Given this list of marker genes ANAPC16, EDNRA, ASPM, GK2, INHBB, SRC, TEX101, ADGRG2, NLRP14, SPAG4, TUBGCP4 (NCBI Gene Id 27229), NCAPH, HOXA10, RPS6KB1, GALNT3 (NCBI Gene Id 2591), ZP4, STK33, ATP2B4, TESK2, PACRG, ZNF296, SHCBP1L, GDF9, MYH9, ETV6, SLCO4C1, CCIN, ARID4A, SKA3, ANKRD31, PAIP2 (NCBI Gene Id 51247), IQCG, SPATA9, ZBTB16, RBP4 (retinol binding protein 4), DRC1, USP17L2, TARBP2, PRKAG1, PARN, TRIP13, YIF1B, AP3B1, ZSCAN2, SSH2, ORC4, DEFB1, H1-9P, LHCGR, AFP, EPC1, TNP1, SPAG16, DUSP13B, HMGB2, SGO2, CATSPER4, PRDX4 (peroxiredoxin 4), CFAP61, SPATA31D3, C3orf62, PGM3, DLEC1, ZFP57, CENPX, ADAM32, PHC2, TSPY1, KMT2D, TYRO3, HUS1B, PPP3R2, MFSD14A, CDC25B, TGFB1, RAD21, TTLL3, XKRY, NUMA1, MYCN, FMN2, PLN, DNMT3A (DNA methyltransferase 3 alpha), PROK2, MORN2, NPR2, REDIC1, TSNAXIP1, FKBP6, HPGDS, ATAT1, GPR149, TDRD5, AGFG2, ACRBP, KIFC1, CFAP53, UBE2J1, CRTAP, DAZ1, ELSPBP1, EED, ZFP42, GGT1, ANTXR2, DDX3Y, GJA10, OOEP, C14orf39 (NCBI Gene Id 317761), CTCF, PMFBP1, IMMP2L, SIRT2, STAG3, MEIOSIN, ADAD2, B4GALNT1, GOLGA2, FNDC3A, SUFU, FAM9C, AXL, SPACA1, MYCBPAP (MYCBP associated protein), CATSPERB, PTTG1, HOXA9, SYNE1, TDRD9, FANCG, XRCC2, SPATA31A6, ATM, HSF5, CFAP119, DNMT3L, EIF2S2, DDX25, DEFB126, PTTG3P (NCBI Gene Id 26255), FAM170A, TTLL5 (NCBI Gene Id 23093), GAMT, RBM46, BCAS2, DCST1, DAZAP1, RIMBP3C, HSPA1L, UBB, ARID4B, MDK, PRDM14, BCL2L10, HERC2, WFDC2, PRKACA, DEAF1, IFTAP (intraflagellar transport associated protein), ASZ1, CDC23, C2CD6, SOHLH1 (NCBI Gene Id 402381), ZCWPW1, DDX4, STK11, STRBP, KATNAL1, KASH5, RAD1, CDC25C, PTX3, TTC21A, ZAR1, SMAD4, SKIL, RAD51D, TBP, WDR77, ATN1, LRRC8A, SPACA3, PTTG2, RAD23B, UBE2Q1, IGF2R, MORC1, KLK14, NCAPD2, SPESP1 (NCBI Gene Id 83599), SLC2A8, ZNF830, NPPC, CT55, UBXN8, PIWIL3, TBC1D21, BRD2, H3-3A, NANOS2, SPIN1, PLB1, DCAF13, RBM7, SLC26A3, ACE, AR, CDK1, PDCL2, RAB24, BPY2B, WASHC5, ADAM20, ANAPC5, PPP1CC, DMRT1, PMCH, NEURL1, HORMAD2, SNU13, ZC3H14, ZW10, LGR4 (NCBI Gene Id 55366), NR2F2, FST, ARMC3, DLD, GARIN1B, SHB, KAT5, TTC12, PRKG1, PRR19, CCDC38, H3-3B, FAM9B, RNF151, HEXA, CTNNB1, CCNB1, MGAT4D, CCNE2, OR10J1, SPATA6L, TEX15, SPACA5, ANAPC13, RBX1, COX7B2, ADAMTS16, DIAPH2, NR0B1, HROB, SPACA6, H2BC1, BRDT, SPO11, HOATZ (NCBI Gene Id 399949), NME5, YY1, BCL2L2, ANG, FOXO3, KDM3A, USP26, ARMC2, GJA1, YTHDC1, RNF2, GSK3A, ZFP41, FAM50A, ASH1L, SERPINA5, KHDRBS1, CDC25A, CDC27, DZIP1, OSBP2, TRPC3, YTHDF2, MEI1, TUBG2, USP9Y, PLCD4, SYCE1, TSPY2, ADGB, WEE2, RAD21L1, NR2C2, VDAC2, PRM3, ETV5, PTCH1, ANKRD49, APOB, WNT3, MAST2, BPY2, ACTR2, TTLL8, TMEM232, RAD51, HEXB, HERPUD2, ZNF318, DAZ3, SPIRE1, PDILT, OR1D2, GHSR, BRME1, DUSP1, CALR3, FBXO5, SIRT1, SMC2, RXFP2, DND1, UTP14C, CRKL, DAZ2, DHX36, UPF3A, TTLL1, M1AP, PRSS37, FAM209A, AAAS, GLIPR2, TCFL5, TOP3A, CDC16, SHISA6, ZP2, METTL14, NSUN2, CCNYL1, SLC2A14 (solute carrier family 2 member 14), DDX3X, LIMK2, CRISP3, SPATA31A5, SPATA31A1, SPACDR, CCDC136, CALR (NCBI Gene Id 811), NEK2, TOP6BL, FIGNL1, DRC7, MOS, SPANXB1, PTGDS, PKDREJ, ADIG, ESPL1, SPAM1, TBPL1, VIPAS39, FOXL2, AURKA, WDR33, CFAP57, CCT4, MLH1, SEPTIN1, CYLC2, TPPP2, TOPAZ1, ODF4, ACVR2A, EREG, SYT6, FIGLA, ALDOA, SGPL1, RACGAP1, LYZL4, CCDC62, WIPF3, PFN4, BBS4, SUN1 (Sad1 and UNC84 domain containing 1), RPL39L, LRRK2, GLIPR1, LHFPL2, USP9X, PSMD13, TSPY9, PLK1, NDRG3, ZNF148, CATSPERG, PSMA8, MSX1, DCAF17, CFAP65 (cilia and flagella associated protein 65), MCM9, SLC26A8, RUVBL1, TUBB8, SOX8, TAF7L, AKT1, SPATA31C1, ADCY3, SPEM3, SPACA7, SLIRP, SGO1, LARP7, ACTL7A, FANCL, TBC1D20, GGN, PIAS1 (protein inhibitor of activated STAT 1), SEPTIN7, DNAAF3, STRA8, BRCA2, PPP2CA, KLHL10, UNC13B, TSGA10, IZUMO1R, CFAP69, REC114, INCENP, PYGO2, BMAL1, STAT3, TEX14, MAK, SPMAP2, PRSS55, PIWIL1, SYCE1L, SLX4, SPINK13, IFT81, STAG2, CELF4 (CUGBP Elav-like family member 4), ANAPC15, TOP2A, STAU2, PPP2R1A, PRKACG, CATSPERD, SPA17, RAD54B, FETUB, TUBGCP6, NR5A2, KIAA0319L, TDRKH, SPATA46 (spermatogenesis associated 46), CCDC146 (coiled-coil domain containing 146), SMC3, ICA1L, AFG2A, ZNF541, VPS54, TEX11, SETX, ADAMTS2, CFAP221, ZNF449 (NCBI Gene Id 353278), MLH3, TSPY4, SCAPER, ATP8B3, PRMT7, ASF1B, PLEKHA1, BAX, CEP131, TOP2B, PCYT1B, UBE2B, SEPTIN6, H1-8, FOXC1, GMCL2, CCDC63, AGFG1, NEURL4, INSR, SOHLH2, ANKLE1, FSIP2, H3-4, SUN2, CTCFL (CCCTC-binding factor like), SPATA31A7, CCNB2, LIN28A, CNTLN, JAM2, GLI1, TCP1, C1orf146, SERPINA10, H1-1, NANOS3, FOXJ1, SPAG8, CCT5, CHD5, NOX5, C9orf78, EDN1, YTHDC2, TXNRD3, QKI, MTA2, CDKN1C, YBX2, RAD51B, NCAPD3, COL6A1 (collagen type VI alpha 1 chain), SPATA32, VPS13B, ROPN1, MCM8, SYCP1, PUM1 (NCBI Gene Id 9698), DAZL, LIF, TERB2, HMGA2, MND1, ANAPC4, OSGIN2, LLCFC1, FCRL5, CFAP206 (NCBI Gene Id 154313), NBN, ADAM7, NDN, PDIK1L, FREY1, PAEP, EHMT2, KRT9, CHFR, TCP11X1, OVCH2, CBY3, CABS1, MEIKIN (NCBI Gene Id 730865), PLCZ1, CETN2, PYGO1, ITPR1, PKMYT1, SUN5 (NCBI Gene Id 140732), CCDC34, TRIM75, TGFBR1, RAD51AP1, NTRK1, ZPBP2, FBXO24, ZP3, CGB3, LEPR, PCDH11Y, GPX4 (glutathione peroxidase 4), DPCD, CENPC, GNPDA1, RB1, INPP5B, TMEM81, TRIM36, TNP2, PGAM2, SPATA6, INTS13, BBS1, CCDC159, ACTL9, CIB1, FUT6, OVGP1, ACTR3, NICOL1, MMP19, NODAL, CGB7, FSHB, CHN2, GPR3, TBATA (NCBI Gene Id 219793), SASS6, RNF212B, BBS2, ITGB1 (NCBI Gene Id 3688), TUBGCP2, OR7C1, RNF114, CREB3L4, ASTL, MSH4, KNL1, SOD1, DDX20, CLOCK, SKA1, BRIP1, CCNE1, MMP2, CCNY, SYT8, TAF1L, RAN, OAZ3, CFAP58, CCNB3, MEI4, SYCP2, PGR (NCBI Gene Id 5241), SPIN2B, KIT, KCTD19, OR2H2, H1-7, CDC20, DNALI1, CELF3, RNASE10, ANAPC10, CCDC87, MTOR, MEA1, RFX2, EME2 (NCBI Gene Id 390668), SPATC1L, PLCB1, NKAPL, ADAM29, H1-6, CCDC42, CFAP97D1, SIRT7, NECTIN2, NOBOX, PAFAH1B3, MCIDAS, SLC19A2, SLC4A2 (NCBI Gene Id 96677), TSPAN8, KLC3, TUT7, GTSF1, FANCD2, SEPTIN2, FSHR, TPGS1, ADAM2 (ADAM metallopeptidase domain 2), TOB2, LRGUK, FANCM, MRE11, AGO4, HFM1, PTGDR2, HOXA11 (NCBI Gene Id 3207, homeobox A11), FAM170B, SKA2, PRM2, RNF17, IL12B, LSM14B, CNBD2, ZDBF2, CCT3, NANOS1, TXNDC2, STAU1, FOXJ2, BTBD18, RPS6KA2 (ribosomal protein S6 kinase A2), WT1, SEBOX, MEIG1, ZNF628, CENPS, SPINK2, MFGE8, DKKL1, POC1B, GALNTL5, ARRDC5, KAT8, WNT5A, C16orf92 (NCBI Gene Id 146378), CATSPER3, ADCYAP1R1, GLRB, MSH2, KDM5B, SYCE2, ROS1, TMPRSS12, TP63, SLC9B1, SLC9C1, OVOL1, MASTL, PAQR5, CD46, SPATA31D4 (SPATA31 subfamily D member 4), TMEM203, PSMC3IP (NCBI Gene Id 51769), SPATA31A3, HUS1, KIF18A, CELF1, RAD54L, TRIM27, CTSH, ROPN1L, SPIRE2, GLIPR1L1, TERB1, NME8, SPPL2C (signal peptide peptidase like 2C), BCL6, SMC1B, CADM1, SHOC1, DHH, ODF2, SOS1, ARMC12, CKS2, PLD6, TSPY10, NRIP1, ODAD3 (outer dynein arm docking complex subunit 3), TSSK4, UBR2, BMPR1B, PTN, PCSK4 (NCBI Gene Id 54760), TMEM95, ADAM21, TSNAX, FOLR3, JAM3, LRRC46, BAG6, DEDD, NOS3, PAX5, SOX9, BCL2L11, SPATA25, SPINK1, FOLR2, DDX6, CFTR, NLRP5, ZAN, TCP11X2, CXADR, NELL2, SFMBT1, CDYL, TRIM28, RBMY1B, MSH5, FAM209B, CCR6, NUP210L, ERCC1, TSPY3, LGR5, BUB3, CDC26, MYBL1, TRPC6, RARA, SOX30, CDY1B, CCT8, WDR48, CLDN11, SPEF2, CIMAP1A, HOXD9, AKAP4, ALKBH5, PARP11, PIWIL2, PAFAH1B1, ZFY, CFAP91, DPY19L2 (NCBI Gene Id 283417), SPIN3, LZTFL1, XRN2, RHBDD1, FXR1, ADCY10, GARIN1A, ADAM18, DMC1, TUBA8, MECP2, STX2, NOTCH1, INHBA, DEFB118, TUT4, PANK2, GGNBP1, ATRX, PDE3A, FCRL3, KLHDC3, PSME4, DNHD1, RPL10L, LEP, TDRP, SYCP3, SMAD5, RSPH1, SIX5, ADAM28, FBXO43, SELENOF, SLC25A31, ROPN1B, SPMIP7, PRSS42P, SRPK1, TCP11, MNS1, MST1R, TMF1, CATSPER2, ABHD2, JAG2, EIF5A2, IGF2, SPIN2A, SPATA19, PARK7, TPST2, MERTK, RSPH6A, MEIOB, FOLR1, P3H4, MCMDC2, RAD51C, GGNBP2, VGF, SSX1, TEX46, CATSPER1, TSSK6, RPA1, CCNI, NDC80, TDRD12, SPTBN4, PLAT, DYNLL1, SPAG17, TESMIN, GAL3ST1, DIRAS3, HADH, DAZ4, INSL3, IHH, TTK (NCBI Gene Id 7272), CAPZA3, IFT25, WDR54, SPACA4, EIF4G3, CATSPERZ (catsper channel auxiliary subunit zeta), RNF8, NPM2, EIF4H, CD9, ZSCAN21, HYAL3, TESK1, UBE3A (NCBI Gene Id 7337), ZPBP, IHO1, NUF2, ADAMTS1, TAF4B, RIMS1, SPATA2, HOXD10, SLC22A16, ZWINT (NCBI Gene Id 11130), REC8, NPHP1, BNC1, IFT20, ANAPC2, DDB1, DPY19L2P2, SEPTIN4, PRDM9, GMNC (NCBI Gene Id 652527), GLRA1, EXO1, RAB3A, ZMYND15, ZAR1L, SMC1A, BSPH1, CECR2, HERC4, IZUMO3, NCAPH2, EFCAB9, HSF2BP, MYCBP, NR6A1, VDAC3, BCL2L1, FOSL1, UBAP2L, TUBG1, STK35, SPATA31E1, BMP15, CFAP44, MUS81, OCA2, BCKDK, VCX, CATSPERE, SPDYA, HVCN1, SEPTIN12, EQTN, ACR, LCN6, CTDNEP1, FBXW11, ODF1, PRM1, PAQR8, ZMYND12, MKKS, CFAP43, NPAP1 (nuclear pore associated protein 1), OOSP2, SPANXA2, RMI1, EME1, ZGLP1, CIBAR1, TEX12, TNFAIP6, SMC4, MARF1, IFT27, SMAD1, MAPK15, IQCF1, NDC1, SPIN4, AKAP3, HORMAD1, UMODL1, TERF1, RIMBP3B, CDY2A, SPATA22, BIRC3, ANAPC11, SLC26A6, TXNDC8, MKRN2, TDRD7, CRISP1, RAD50, AZIN2, GAS2, BCL2, WNT4, H2AX, CCT2, METTL3, PATZ1, CCNA1, SLC22A14, PRND, AURKC, PANX1, CREM, BBOF1, BMP4, MEIOC, IGF1, SOX17, IQCH, PTEN, KDM1B, CSNK2A2, CNTD1, SLC9A8 (solute carrier family 9 member A8), RAI14, SPAG6, PRSS21, MOV10L1, CUL4A, PAQR7, POC1A, SPATA31C2, RGS2, MAJIN, SPATA20, SPMIP6, CFAP54, CABYR (NCBI Gene Id 85304), ZMIZ1, MROH2B, ACRV1, USP42, LY6K, SMCP, IRAG2, RIMBP3, YBX3, SPATA24, FER, WBP2NL, ACVR1, PRDM1, SSTR1, AXDND1, CLGN, GARIN3, AMH, SPACA5B, CCNB1IP1, BTG1, SEPTIN14, RNF212, MSX2, IQCN, SPAG1, BCAP31, FAM9A, ING2, ATP1A4, FOXA3, TUBGCP3, ZNF35, FANCA, CCER1, B4GALT1, AFF4, CYP26B1, SPATA16, GARIN4, E2F1 (NCBI Gene Id 1869), UCHL1, CFAP157, IFT56, TSSK3, FUT10, PITHD1, SMARCA2, BPY2C, PLA2G10, LYZL6 (NCBI Gene Id 57364), SPEM1, STXBP1, SELENOP (selenoprotein P), IZUMO1, SEMG1, GORASP2, CEP57, ANGPT2 (angiopoietin 2), CEP128, ANAPC1, EXD1, CCT7, DNAH1, DCST2, SIAH1, ACOX1, HPGD, ZP1, ACSBG2, ADAD1, CDK2, HOOK1 (NCBI Gene Id 51361), CDY2B, SPATA31D1, DMRTC2, CCNO, PIK3CA, CLIC4, CFAP47, HSF2, FZR1, TEX19, NECTIN3, TLE6, IQUB, MSH6, GMCL1 (NCBI Gene Id 64395), SPAG11B, PAFAH1B2, ERCC4, PNLDC1, TDRD1, TSPY8, SNRPA1, CACNA1H (NCBI Gene Id 8912), TSSK2, HSPA2, SPANXA1, CRISP2, SBF1, RBBP8 (NCBI Gene Id 5932), GLIPR1L2, TMEM119, TDRD6, LFNG, TUBGCP5, IGSF8, MAEL, PIWIL4, KDM2B, PLA2G3, ANAPC7, CDY1, SPOCD1, ELL3, TRPC7, HSF1, CFAP52, TSSK1B, SYCE3 (NCBI Gene Id 649274), CYLC1, CDK16, FOXJ3, SEMG2, BOLL, here is a description of the gene set: studied in species Homo sapiens Human Gene Set: GOBP_SEXUAL_REPRODUCTION A type of reproduction that combines the genetic material of two gametes (such as a sperm or egg cell or fungal spores). The gametes have an haploid genome (with a single set of chromosomes, the product of a meiotic division) and combines with one another to produce a zygote (diploid).